The following is a description of a gene set: part of: Gastrulation species: Homo sapiens Reactome Pathway: Formation of paraxial mesoderm Skeletal tissues originate from paraxial mesoderm, lateral plate mesoderm, and neural crest. Paraxial mesoderm is produced by invagination of cells through the primitive streak and is the precursor of somites, which are spheres of mesenchyme bounded by epithelium that bud at fixed intervals from the anterior paraxial mesoderm in a process termed somitogenesis. Somites give rise to the axial skeleton and skeletal muscles.<br>Paraxial mesoderm becomes specified at a lower level of BMP signaling that results from the interaction of BMP4, produced by the lateral plate mesoderm, with NOGGIN (NOG), a negative regulator of BMP signaling produced by the notochord. WNT signaling by WNT3A that activates beta‑catenin (CTNNB1), FGF signaling that acts though FGFR1, and TBXT activate expression of TBX6 and Mesogenin 1 (MSGN1). MSGN1 binds and activates SNAI1 to promote epithelial-mesenchymal transitions (EMT). TBX6 activates MSGN1, and MSGN1 activates TBX6, to establish a positive feedback loop that ensures commitment to the paraxial mesoderm lineage. TBX6 and MSGN1 act with WNT signaling to activate expression of MSGN1, and the NOTCH ligand Delta‑like 1 (DLL1), which enhances NOTCH signaling. MSGN1 binds and activates expression of DLL1, DLL3, NOTCH1, and NOTCH2, and binds to Clock enhancers that regulate periodic expression of LFNG during somitogenesis in the anterior paraxial mesoderm. The counterbalancing DLL3 protein inhibits NOTCH signaling by binding NOTCH1 in endosomes and targeting NOTCH1 for lysosomal degradation.<br>TBX6 alone is capable of reprogramming pluripotent stem cells to paraxial mesoderm and acts in a regulatory loop with MESP2 to create the boundaries of nascent somites: TBX6 activates expression of MESP2 which then represses TBX6 by targeting TBX6 for degradation, leaving MESP2 alone at the segmental boundary., and this is the list of marker genes: WNT3A, PSMB5, KAT2B (NCBI Gene Id 8850), PSMD14, DLL1, PSMD13, PSMC1, PSMC2, ADRM1, PSMD7, TBXT, PSMA4, MAML3, PSMA3, DLL3, PSMB4, PSMD11, PSMB6, LFNG, NOG, MAML2, SNW1, CTNNB1, TBX6, PSMD8, MAMLD1, PSMC5, PSMB2, KAT2A, MESP2, MSGN1, MAML1, PSMA5, BMP4, FGFR1, PSMC4, LEF1, PSMD6, HES7, PSMA7, PSMC3, RBPJ, PSMA6, PSMD1, PSMB3, PSMB1, PSMA2, NOTCH1, CREBBP, PSMD12, EPHA4, PSMC6, PSMD3, PSMB7, EP300, PSMA1, RIPPLY2, PSMD2, SEM1